The following is a description of a gene set: Mouse Gene Set: GOCC_COPII_COATED_ER_TO_GOLGI_TRANSPORT_VESICLE studied in species Mus musculus A vesicle with a coat formed of the COPII coat complex proteins. The COPII coat complex is formed by the Sec23p/Sec24p and the Sec13p/Sec31p heterodimers. COPII-associated vesicles transport proteins from the rough endoplasmic reticulum to the Golgi apparatus (anterograde transport)., and this is the list of marker genes: Sec23b, Vti1b, Lman2, Ergic2, Pef1, Sar1b, Cideb, Lman2l, Sec31a, Cnih4, Ecpas, Tmed5, Scap, Vma21, Tmed2, Sec16a, Yipf6, Sec24a, Tmed6, Tmed4 (transmembrane p24 trafficking protein 4), Pdcd6, Sec13, Klhl12, Yif1a, App, Slc30a5, Golga2, Tmed9, Uso1 (USO1 vesicle docking factor), Surf4, Tmed1, Tmed10, Yif1b, Sec24c, Sar1a, Ergic1, Tmed3, Tmed11, Yipf5, Sec16b, Ergic3, Sec23a, Sec31b (NCBI Gene Id 240667), Ddhd2, Vti1a, Srebf2, Sec24d, Tex261, Lman1, Vangl2, Pcsk9, Ier3ip1, Tmed7, Srebf1, Sec24b, Sec22b, Stx17, Sec23ip, Gosr2, Lman1l